The following is a description of a gene set: Human Gene Set: GOBP_CARBOHYDRATE_IMPORT_ACROSS_PLASMA_MEMBRANE studied in species Homo sapiens The directed movement of a carbohydrate from outside of a cell, across the plasma membrane and into the cytosol., and this is the list of marker genes: SLC2A1, SLC2A10, SLC5A1, SLC5A2, SLC2A5, SLC2A3